The following is a description of a gene set: part of: TNF signaling Activation of tumor necrosis factor receptor 1 (TNFR1) can trigger multiple signal transduction pathways to induce cell survival or cell death (Ward C et al. 1999; Micheau O and Tschopp J 2003; Widera D et al. 2006). While pro-survival signaling is initiated and regulated via the activated TNFR1 receptor complex at the cell membrane, cell death signals are induced upon the release of TRADD:TRAF2:RIP1 complex from the membrane to the cytosol where it forms death-inducing signaling complex (DISC) (Micheau O and Tschopp J 2003; Schneider-Brachert W et al. 2004). Upon apoptotic stimulation procaspase-8 or 10 is recruited into the DISC, and close proximity promotes the dimerization, autocatalytic processing, and activation of the initiator caspase-8 (and/or caspase-10) (Wang J et al. 2001; Boatright KM and Salvesen GS 2003). The initiator caspases then process and activate the downstream effector caspases such as caspase-3 in a proteolytic cascade (Stennicke HR et al. 1998). The effector caspases in turn cleave many diverse substrates, ultimately inducing cell death. Reactome Pathway: TNFR1-induced proapoptotic signaling studied in species Homo sapiens, and this is the list of marker genes: BIRC2, RNF31, SHARPIN, IKBKE, RBCK1, FADD (NCBI Gene Id 8772), TNFAIP3, TNF, USP2, USP21, OTUD1, TRAF2 (NCBI Gene Id 7186), TBK1, XIAP, UL36, MIB2, TRADD, USP4, RIPK1, TNFRSF1A, CASP8 (caspase 8), OTUD7B, SPATA2, OPTN, BIRC3, CYLD